The following is a description of a gene set: Any process that activates or increases the frequency, rate or extent of protein localization to Cajal body. Human Gene Set: GOBP_POSITIVE_REGULATION_OF_PROTEIN_LOCALIZATION_TO_CAJAL_BODY species: Homo sapiens, and this is the list of marker genes: CCT7, CCT6A, CCT4, CCT2, CCT3, LARP7, CCT8, TCP1, MEPCE, CCT5